The following is a description of a gene set: Human Gene Set: GOBP_PROXIMAL_DISTAL_PATTERN_FORMATION studied in species Homo sapiens The regionalization process in which specific areas of cell differentiation are determined along a proximal/distal axis. The proximal/distal axis is defined by a line that runs from main body (proximal end) of an organism outward (distal end)., and this is the list of marker genes: GLI1, OSR1, IRX3, HOXA9, IRX2, CHSY1, HOXC10, DLX1, CTNNB1, ALDH1A2, SP8, PBX2, DLL1, HOXD10, GLI2, PBX1, SIX3, HOXC11, HES5 (NCBI Gene Id 388585), DLX2, HOXD9, HOXA11, NODAL, TP63, EN1, HOXC9, GLI3, GREM1, CYP26B1, HOXB9, HOXA10, LRP4, FGF10, IRX1